Given this list of marker genes KY, DST, CHST3, COMP, DVL1, FGFR3, here is a description of the gene set: species: Homo sapiens Limited hip extension Limitation of the extension of the hip, i.e., decreased ability to straighten the hip joint and thereby increase the angle between torso and thigh; moving the thigh or top of the pelvis backward. Human Gene Set: HP_LIMITED_HIP_EXTENSION